The following is a description of a gene set: Human Gene Set: GSE21546_WT_VS_SAP1A_KO_ANTI_CD3_STIM_DP_THYMOCYTES_UP from publication Costello P, Nicolas R, Willoughby J, Wasylyk B, Nordheim A, Treisman R (PMID 20554967) Removal of the transcription factor SAP1a member of the Ternary Complex Factor (TCF) group of transcription factors which in conjunction with Serum Response Factor (SRF) has been shown to have a profound effect on positive selection in the thymus. When another TCF Elk1 is knocked out in mice there is no effect on positive selection unless it is on a Sap1a KO background where the phenotype is very severe. We have stimulated isolated double positive T cells (DPs) with anti-CD3 to mimic positive selection and compared basal and stimulated transcription across the four genotypes to discover the downstream targets of Sap1a involved in positive selection. Genes up-regulated in double positive thymocytes stimulated by anti-CD3: wildtype versus ELK4 knockout. studied in species Homo sapiens, and this is the list of marker genes: RAPGEF3, MANF, UBD, SLC34A1, DNAJB11, SPACA7, ZNF385C, GNG12, LDHB, SLC22A4, BAG3, ARL6IP4, NOMO1, NCALD, MYDGF, SRM, NAPEPLD, ALG10, SLC25A16, RGS4, PRTN3, SAP18, VPS53, ALDOA, MARS2, HAPLN2, PLAC8, CFB, MRAP, SPRYD4, GJB1, HIF1A, KPNA1, TMX4, OLA1, MRPL37, RFLNB (refilin B), RETSAT, GORASP2, IDH1, RASGRP2, VANGL1, MIR22HG, PPM1F, ANXA3, ERN1, HK3, PAPSS2, CSF2RA, SVIP, PFAS, H2AC18, EBNA1BP2, SOS2, RNF217, RPS6KA2, SNRNP35, PLP1, SGTA, COL5A3, NOP10, TMED3, AREL1, MEGF9, C14orf119, TENT5A, CERS6 (NCBI Gene Id 253782), PDCD4, ERLIN1, GATAD2A, CISD3, STOM, DBX2 (NCBI Gene Id 440097), H2AJ, PSTPIP2, MPO, PPP2CB, SLC25A18, PPP1R14D, ANTXR1 (NCBI Gene Id 84168), EMC4, MOGS, IGSF6, SERPIND1, CTSG, CHSY1, HSPA5, DDX18, C4orf19, ATP6V1C1, NDUFS6, F10, DAD1, MS4A3 (membrane spanning 4-domains A3), B4GALNT1, TBRG4, CLCNKB, DDX21, CFAP65, CRY1, KDELR2, HERPUD1, TALDO1, HTR1F, RAB21, GMPS, NKG7, MAP3K14, FGL2, GSTM5, MTFP1, EDEM1, MTR, GPR160, MCU, P4HB, SPAG8, AKR1C3, H6PD, IFT57, HSD11B1, ALAS1, PGK1, PRKAR2A, FCGR2A, CST7, MSRB1, CEACAM21, TMEM147, HEPACAM2 (NCBI Gene Id 253012, HEPACAM family member 2), RIMBP3C, GPR83, LRG1, SRGN, NECTIN3, MXRA7, CD8A, TUBB3, TMEM167A, GRPEL1, BCAS1, ADSS1, NOL8, FCGR2B (Fc gamma receptor IIb), TRNT1, TEX2, SSR2, OLR1, CYB5R4 (cytochrome b5 reductase 4), AIMP2, RHOJ, QTRT1, TNK2, PTGR1, GALNS, KRTAP11-1, GLRX, PABPC4, PPEF2, ZNF475, DMKN, LRP3, OTOF (otoferlin, NCBI Gene Id 9381), LYG2, WNT7B, ENO1, AOAH, ANP32E, ATP8B4, ARHGEF19, SPNS3, NT5C, ROR2, BHLHA15, RNF185, SLC33A1, TYROBP, ACTN2, ATF2, CD69, HSPA2, ELANE, UBASH3A, TLR4 (NCBI Gene Id 7099), S100A9, NOL6, MST1, UBE2A, CAMKV, FUCA2, PFKP, PDIA5, MRPL35, TRIM45, BRI3BP, KATNBL1, RAB11FIP4, CELSR3, SEMA4A, FAM90A13